The following is a description of a gene set: species: Mus musculus Any process that modulates the frequency, rate or extent of the change in the membrane potential of the mitochondria from negative to positive. Mouse Gene Set: GOBP_REGULATION_OF_MITOCHONDRIAL_DEPOLARIZATION, and this is the list of marker genes: Parp1, Dcn, Rack1, Rbfox2, Myoc, Gclm, Got1, Hsh2d, Bok, Cck, Adcy10, Ppp2r3c (protein phosphatase 2, regulatory subunit B'', gamma), Abcd1 (ATP-binding cassette, sub-family D member 1), Fzd9, Src, Tspo, Lrrk2, Kdr, Mllt11, P2rx7, Oga, Alb, Gclc, Ngfr, Alox12